Given this list of marker genes PHLDA2, CIR1, ZBTB32, FEZ1, OAS3, NFS1, PNKP, PRICKLE3, KLF9, OSMR, here is a description of the gene set: from publication Shiraishi K, Yamasaki K, Nanba D, Inoue H, Hanakawa Y, Shirakata Y, Hashimoto K, Higashiyama S (PMID 16862184) studied in species Homo sapiens Promyelocytic leukemia zinc-finger (PLZF) is a transcriptional repressor and tumor suppressor. PLZF is expressed in melanocytes but not in melanoma cells, and recovery of PLZF expression markedly suppresses melanoma cell growth. Several target genes regulated by PLZF have been identified, but the precise function of PLZF remains uncertain. Here, we searched for candidate target genes of PLZF by DNA microarray analysis. Pre-B-cell leukemia transcription factor 1 (Pbx1) was one of the prominently suppressed genes. Pbx1 was highly expressed in melanoma cells, and its expression was reduced by transduction with the PLZF gene. Moreover, the growth suppression mediated by PLZF was reversed by enforced expression of Pbx1. Knockdown of Pbx1 by specific small interfering RNAs suppressed melanoma cell growth. We also found that Pbx1 binds HoxB7. Reverse transcription-polymerase chain reaction analysis demonstrated that repression of Pbx1 by PLZF reduces the expression of HoxB7 target genes, including tumor-associated neoangiogenesis factors such as basic fibroblast growth factor, angiopoietin-2 and matrix metalloprotease 9. These findings suggest that deregulation of Pbx1 expression owing to loss of PLZF expression contributes to the progression and/or pathogenesis of melanoma. Genes up-regulated in A375 and 397 cells (melanoma) by forced expression of PLZF off adenovirus vector. Human Gene Set: SHIRAISHI_PLZF_TARGETS_UP